The following is a description of a gene set: studied in species Homo sapiens Any process that modulates the frequency, rate or extent of the chemical reactions and pathways involving a protein. Human Gene Set: GOBP_REGULATION_OF_PROTEIN_METABOLIC_PROCESS, and this is the list of marker genes: PLAT, BANK1, TPR, IL15, SELENOT, SRC, NANOS2, CENATAC, CALCA, IL12A, VEGFB, EIF2AK4, DNAAF4, TAOK3, ELP5, FBXO2, NSD1, DDRGK1, APOE, IGFBP5, RPL38, ADARB1, CASS4, SERPINB12, KDR (NCBI Gene Id 3791), WNT7A (NCBI Gene Id 7476), SERBP1, PYM1, RASD2, BIRC8, TCIM, PAIP2, N4BP1, TRUB2, DAPK1, NECAB3, GTPBP4, LIMCH1, NEURL3, BIRC2, SYAP1, SNX1, MIR106B, PARP14, LATS1, FMN2, NUDT15, BCL10, LARP1B, PLCB1, OGFOD1, MAP3K5, SPOPL (NCBI Gene Id 339745), MAGOH, SSH1, GZMB, CEBPA, GAS1, TLR9, SMYD5, ABCG1, CNOT6L, MUL1, MIR181C, NCBP1, YBX3, ECM1, CNDP1, PDCD6, WTIP, ABCE1, MIR19B1, PER2, DHFR, ZBED3 (zinc finger BED-type containing 3), ERBB4, MIR98, ZAR1L, UQCC2, STK4, CLN8, PINX1, MKNK2, RASGRP1, DEFB114, EIF4A3, DUSP7, GAPDH, RWDD3, NCBP2, NOS2 (NCBI Gene Id 4843), CCDC22, FGF7, ELAVL1, PRKCE, JTB (NCBI Gene Id 23561), TCF7L2, HMG20A, MTBP, TRIM40, NCK2, CCR7, NKD2, CUL3, CDKN1B, LARP4, NGDN, FGA, BCAP31, IL20, SH3RF2, PTK2B, TLK2, MAGEA3, FRY, AGO2, FASTKD2, FGF19, AIMP2, ZCCHC13, MIR26B, DYRK1A, CASP3, IL21, SPON1, PAEP, BIN1, PIM1, COPS6, MYLIP, DERL1, MAP3K20, ADCYAP1, METTL3, F8A2, LPCAT1 (lysophosphatidylcholine acyltransferase 1), MAPK9, MIRLET7I, IBTK, TMEM259, MIR181D, SFN (NCBI Gene Id 2810), NEK10, EZH2, LSM14B, NLRP7, RASAL2, USP19, RAB3GAP2, MGAT4D, PUM3, RPS6KB1, PTPN3, TERF2IP, RPL5, IFRD2, WAC, ASB11, NEDD9, JAK2, SQSTM1, CD81, AGO3, RDX, MSI1, CNOT2, RNF185, PAXIP1, IL23R, USP4, ENC1, PFDN2, GCLC, ELP2, COP1, FN1, MIR204, PRKCG, CCL5, MIR152, EFNA1, CSNK2A2, TNIK, DHX29, PTPRJ, LILRB2, ASPSCR1, HDAC2, BAG6, HDAC4, PRKACB, ABCA7, CD300A, PLK3, SAMD4A, DIO2, CDKN3 (cyclin dependent kinase inhibitor 3), AKT1, ZNF418, PPIB, MT3, PABPC1, PIH1D1, FAXDC2, CPEB1, MOB1B, CDK5RAP1, TMX1, TP53, ABCA2, IL1B, EEF2K, CARD9, TSG101, SP1, SPINK5, CCNG1, MDM2, CACTIN, TARDBP, TSFM, NOD2, HMG20B, FHIT, PRKACA, OAZ2, UPF3A, FKBP1A, CPEB3, MVP, CAPRIN2, SENP1, DMTN, ITLN1, ERRFI1, TRIB1, LSM14A, CLN3, PLA2G10, MAPKAPK5, ADAM8, PACSIN3, MALT1, CTF1, ACOT8, RANBP9, DBI, GNL3, PABPN1L, PSMC1, PIWIL3, ZER1 (zyg-11 related cell cycle regulator), SUCNR1, CNOT6, EPPIN, ARRDC4, RIPK1, CAV3, UBB, PRLR, LTF, IFNGR1, BTRC, FADD, RFX4, UPF1, INSM1, KIF14, SMO, TIPARP (TCDD inducible poly(ADP-ribose) polymerase), RBM8A, WNT5A, BMP4, TMF1, SCRIB, GPRC5A, SERPINB3, MACROH2A1, MIR133B, KHDRBS1, APCS, MIR181A2, EIF2B4, MAPK7, STRADB, CUL4B, MIR17 (NCBI Gene Id 406952), PDCD4, EFNA3, STRADA (NCBI Gene Id 92335), PTTG1IP, CAPRIN1, SESN2, ELANE, DBNDD2, MIR106A, EIF4E2, RHOBTB3, MMD, PELI2, THY1, ARHGEF5, DHX9, MIR520C, TOM1L1, VPS25, NXN, CEP43, RPS3, DCUN1D5, CCNK, MIR214, TIMP4, DDX25, DDX1, FLOT2, RNFT2, RPS6KA2, PTX3, ITM2B, HHEX, UBE2K, CNOT9, TRIB3, ELP1, METAP2, RGS2, MAP3K4 (NCBI Gene Id 4216), MIR206, ROPN1B, CDC14B, VEGFA, RPS9, GPS1, DACT1, LILRA2, BOLL, ATRAID, ATG7, IKBKG, SVBP, NLRP2B, IRAK3, PSMD14, MIR125A, KLKB1, YWHAG, SPRTN, ECT2, ILF3, ATXN3L, KLHL31, SH3RF3, RAP1A, SERPINB8, IL10, CEP63, CASP8, BAG5, UBE2V1, AZIN1, SNCA, ARL2BP, SECISBP2, CNOT11, IAPP, PAIP1, EIF2A, MAP2K1, RAB1A, KDM4D, CTSA, FYN, COA3, NGRN, CD4, VIP, C2CD3, TSPYL2, BEX3, MUSK, EIF6, ANGPT1, RCC1L, SEPTIN4 (NCBI Gene Id 5414), CTSC (cathepsin C), ADIPOQ (adiponectin, C1Q and collagen domain containing), BEX4, PBK, CD84, PM20D2, ARRB2, NCSTN, C1QBP, PKD1, GSPT1, TNFRSF10A, MIR455, MAD2L2, DIRAS2, MDM4 (MDM4 regulator of p53), EPHA4, HGS, FGF1, NPM1, SERTAD1, COMMD1, RPS4X, PARD3, AJUBA, CDYL, RHOA, PAWR, PDGFRB, SUFU, RAP2C, RAB7A, RTN4, EDN1, CSNK1E, PIWIL1, NSUN5, PML, MIR199A1, DCUN1D2, CCNT2, SERPINE2 (NCBI Gene Id 5270), FLT4, OTUD6B, COPS4, CACUL1, PKIA, PSMD2, HNRNPD, BZW1 (basic leucine zipper and W2 domains 1), MIR134 (NCBI Gene Id 406924), ELP6, FZR1, PPP1R15A, UBA2, MIR339, RAMP1 (NCBI Gene Id 10267), FGFR1, BAG2, EIF4G1, PRG3, NR1H3, MIR29C, MIR874, TRIB2, CR1 (NCBI Gene Id 1378), CST4, PTCD3 (pentatricopeptide repeat domain 3), MIR644A, SRCIN1, ENO1, EIF4EBP3, IREB2, TSPAN15, CWH43, TAB2, FIRRM, TIA1, POLR2G, BACE2, DHFRP1, USP17L2, USP14, AATF, LDLRAD3, RPS7, COPS8, STYX, MIR101-1, CD86, TRIM44, NTRK2, NPPA, DISC1, PADI6, XRN1 (5'-3' exoribonuclease 1), MIR181B1, MIR378A, IGF2BP2, C8orf88, FKTN, BIRC3, TAF7, AIDA, CREBL2, PIK3C3, GPC3, BARD1, ACVR2A, RNF180, ZGPAT, PSMC4, PARP10, DDA1, HPX (hemopexin), UCN, UBE2C, MAP4K2, MIR200C (microRNA 200c), STAT2, COPS7A (NCBI Gene Id 50813), CHP1, TNK2, CNOT3 (CCR4-NOT transcription complex subunit 3), ARRB1, JAK3, SMAD3, TRAF3IP1, HSP90AA1, DEPTOR, TGFB1I1, XRCC5, SHMT1, MIR28, UBXN2A, PIN1, MIR146A, GSN, SEMG1, GADD45A, RTN1, CST3, NNMT, LYN, BCL2, HIF1A, MELTF, COPS3, SGSM3, RALB, ROCK1, MAPK8IP1, NR1H2, ITM2C, FBH1, DAZ1, DAXX, GLG1, RBX1, U2AF2, C4BPA, PDGFA (platelet derived growth factor subunit A, NCBI Gene Id 5154), LAT, DNAJB2, PRSS37, PINK1 (NCBI Gene Id 65018), RPS27L (ribosomal protein S27 like), USP16 (ubiquitin specific peptidase 16), VPS35, PTPN1, AQP11, DCUN1D4, GGA1, EIF5 (eukaryotic translation initiation factor 5), MSN, CNTN2, KRT13, RILP, METTL8, MTPN, APP, PRR5L, PLXNB2, MIR29A, WFS1, ZFP36, DHX36, FAM20A, LCP2, PRNP, CDK5R1, TYMS, PARP16, SRP9, IL23A, DNAJA3, RHBDD1, PSME3IP1, DAOA (NCBI Gene Id 267012), RNF41, SASH1, MIR27A, CASC3, NUPR1, RASSF2, CAB39, ZFYVE28, FBXL20, FBN1, TMED10, PHB1, MIR10B, HSPA5, OSBPL7, VCP, HERC5, MIRLET7A1, COPS9, TNFAIP3, KLF15, EFNA5, SNX6, NSF, TICAM1, FLT1, TPX2, MKNK1, RPL13A, MIR299, DIP2B, KSR1, DEDD, UBE3A, FBXL5, ITGB1BP1, IGF2BP1, RTRAF, MIR132 (NCBI Gene Id 406921), TNP1, ANG, FGR, ETAA1, ZFAND2A, THPO, BRAT1, CHI3L1, NRDC, TMEM98, CSDE1, MAP1A, SAE1, EDNRB, UBR3, KAT5, MIR148A, TIMP3, MIR21, GHRHR, MTA1, PUM2, CENPX, GABARAP, DUSP1, OPHN1, USP13, MIR590, MBP, DRD4, TMEM132A, RNF111, MYDGF, CEP295, USP7, TLR3, HIPK2, LRRTM3, TRNAU1AP, ROCK2, SEMA4D, GRIN2C, PIK3R6, CCNYL1, PLGRKT, KIT, COPS7B (NCBI Gene Id 64708), THBS4, BCL3, CRYAB (NCBI Gene Id 1410), ALKBH3, YBX1, DAB2, RNFT1, EEFSEC, PICALM, EIF1, GSK3B, SMAD4, CSF1, MIR126, DIPK2A, SARNP, TAF9, PUS7, MINAR1, CEP78, TGFB1, SIRT4, ODC1, NUB1, NHERF1, SUMO1, CSNK2B, TNFRSF10B, RNF128, PSENEN, MIR186, PTEN, GIGYF2, PAIP2B (poly(A) binding protein interacting protein 2B), ADGRB1, UBXN1, CBFA2T3, KDM1A, MIR20A, AURKA, EPAS1, SH3D19, ASB5, STK11, PCSK9, DAZ3, RUNX1, MIR153-1, BZW2, SPOCK2, ISL1, RPS6KA3 (NCBI Gene Id 6197), RACK1, USP26, STOX1, CDK5RAP3, GAS6, SOCS5, BLM (BLM RecQ like helicase), RAD23A, COPS5, SOX17, GPER1, CNOT1, FETUB, MALSU1, RASSF5, RPL23 (ribosomal protein L23), SHH, DGAT2, RIPK3, UBE2L3, MAPT, ATXN3, MAPK8, SLC6A9, MMP9, SH3RF1 (SH3 domain containing ring finger 1), CEMIP, EIF2B2, NEURL1, UCHL5, ASPH, CDKN2A, LARP1, LDB1, PRKCD, WASHC1, HSPB1, ALKBH1, PRKAA1, QRICH2, PSMC6, MIR323A, CTSZ, CAMLG, PSMC3, MAGEA2, DIP2A, KBTBD8, ATXN2, GCN1, CLEC3B, IDE, ERBB2, FBXW11, HSPBP1, PLK2, PIWIL4, SYK, SKP2, HSP90AB1, TTC36, TRAF7, ATF4, TNRC6B, ALKBH5, GRIN2A, IFT52, PSMF1, MMD2, ADAR, LARP6, PSME2, LRRK2, INS, TGFBR1, RTN3, TNFSF15, GNA12, LRIG2, FGFR3, FLNA, SLC51B, MIF4GD, RAP2B, PCIF1, OAZ1, TRIM67, SYNCRIP, PASK, TMTC3, TFAP4, NLRC4, RPS6KA1, SNX3, SKP1, FXR1, HSPA1B, CD80, MIR365A, CCDC134, TNFRSF18, S100A10, PTPN2, EIF4E3, RGS14, MIR448, VTN, EIF3B, MIR210 (NCBI Gene Id 406992), MYCBP2, RPUSD4, JMJD4, EIF3E, ARAF, PILRB, HABP4, TM4SF20, HBS1L, TANK, ABCB10, CAMKK2, FANCI, RAF1, CCDC88A, UBE2D1 (NCBI Gene Id 9335), RIPK2, BARHL2, RPS14, PPP1R15B, CIB1, USP25, CSNK2A1, P3H1, KCNE2, MAD2L1, SOX9, GATA1, CNOT7, WNK1, UNC119, MTM1, PRSS22, IER3, MIR659, TBX1, NAT10, SHMT2, MTG2, ATG14, TRAF4, MFSD8, FAM83D, ATG5 (autophagy related 5), ADCY8, PEF1, CNOT10, FECH, APOD (NCBI Gene Id 347), CEP85, CDKN1C (cyclin dependent kinase inhibitor 1C), CLSPN, MIR379, ANGPT4, CHEK2, CSNK2A3, CRIPTO, MIR135B, ACO1 (NCBI Gene Id 48), CDK20, CAV1, NGF, NKD1, IL1R2, BTG2, SENP2, ZDHHC2, LIPG (NCBI Gene Id 9388), RTN2, RECK, KLF2, USP5, CSTB, EIF4A2, PRKN, PFDN1, EIF5AL1, RPS2, AGAP2, WBP1L, XPO1, RARRES2, LRP1, ROPN1, BEX2, SLIT2, CYFIP2, FXYD1 (NCBI Gene Id 5348), LRP2, SMURF1, EIF4EBP1, PARK7, FLCN, LAPTM5, SOCS4, MIR345, MIR200B, HUWE1, AIRE, EGF, CAPN3, CDC37, HES1, RAD23B, NRG1, EIF2AK2, UBE2S, NANOS1, TRAF3, EIF3H, MIR499A (microRNA 499a), TRIM27, CYFIP1, NPTN, DESI1, BMAL1, CRTAP, PERP, FBXW8, RABL3, TENM1 (teneurin transmembrane protein 1), EEF1A2, MIR6086, WDR91, MIR361, EIF2AK3, RBMS3, EIF5B, NEDD4L, CREBRF, DAPL1, CRY1, TCF25, SPDYA, VBP1, TNFSF12, PKP3, TRIM71, TSPAN17, PIK3R5 (NCBI Gene Id 23533), EP300, CELF1, SEMG2, RFPL1, LRPPRC, EGR1, PRKCH, IFNG, TRAF6, PARL, PDCL3, COPS2, SERP1, MIR145, DCUN1D3, EPRS1, LAPTM4B, TIMP1, ZAR1 (zygote arrest 1), SIRT7, ELOB, PDGFB, SPOP, TSPO, CSF1R, ELP3, ZNF706, GPS2, PPIA, ATP5IF1, F8A1, NDFIP2, MIR212, F8A3, PRMT1, DIRAS3, CTIF, RCHY1, PURA, TRAF2, DTL, RYBP, MIR939, UPF3B, MSI2, ISG15, NANOS3, ROPN1L, DNAJA1, IL34, EIF1B, BIRC7, BBS7, CDH1, PIAS3, AMER1, USP44, SERPINB9, GLMN, BMP2, CHFR, MIR29B1, MIR15B, PIAS1, DCAF1, ANXA2, SERPINE1, MIURF, EGLN2, PKMYT1, TPD52L1, TRIM32, TMEM168, VPS28, BRMS1 (NCBI Gene Id 25855), MRNIP, SNX9 (sorting nexin 9), MAP3K7, SMG8, BMI1, CEACAM1, FBXO33, MIR100, PSME1, EEF2, IGF1, OAZ3, CNKSR3, FOXO3, CENPS, GIPC1, MTG1, SPOCK3, GBA1, CALR, ABL1, FBXO5, TF, GGA3, IVNS1ABP, PTPN13, ARHGAP5-AS1, TARBP2, CDC20, ALAD, MAPK1, GSAP, PKP1, AGO1, AKT1S1, MIR205, MIR15A, BRAF, GRN, GTF2H1, PRELID1, RARA, WARS1, AGBL4, SYNPO2, NQO1, ZNF598, HSPG2, EIF5A, IL33, CHRNA7, MIR503, CCAR2, LATS2, BAK1, PFDN5, MIR128-1, ITGAV, AKTIP, PROM2, WNT1, FBXW7, FANCM, CDK5R2, KLHL40, CDKN1A, RGP1, ERN1, CLU, GFAP, CUL4A, MIR520E, CORO1C, HDAC3, TRAP1, UHMK1 (NCBI Gene Id 127933), HERPUD1, CSPG4, AGER, PSME3, INPP5E, FMR1, XIAP, OSM, DDR2, CENPE, STK38, RHBDF1, PHF20L1, CPEB2, TOLLIP, PAK2, INHBA, ELP4, ARRDC3, CDC20B, CCNY, FOXF2, TSPYL5, DAPK3, RAPGEF2, GEMIN5, PFDN4, UNK, QKI, NFE2L1, MAP3K11, GSKIP, TBC1D7, TIFAB, ERCC6, CCBE1, SH3BGRL, TFR2, CCL21, MAP2K2, BCCIP, SEC22B, YTHDF1, HIPK3, EIF4H, WDFY2, SLC25A37, EIF2B5, NECAB1, TPPP, SERPINB13, MIR103A1, YTHDF3, NDUFA13, LACRT, NELL1, FGFR4, ACER2, METTL18, SIRT6, PSEN1, MIR218-1, NOLC1, ENSG00000293600, NCK1, PRMT3, SVIP, RIC1, ITCH, FGF2, CDK5, GOLGA2, LILRA5, PAQR3, PANO1, ITGB3, EIF2AK1, TSPAN5, PRKAA2, IGFBP3, MPV17L2, MIR877, CHMP6, TRIM6, CD74, EIF4ENIF1, FAM161A, ITGB2, TXN, SERPINB4, CARD14, METAP1, RCN3, MIR144, ZFP91 (ZFP91 zinc finger protein, atypical E3 ubiquitin ligase), PIBF1, CSNK1D, RBM4, CIRBP, ABI1, MIR27B, MTIF2, HRURF, AGO4, LIMD1, MIR346, SPHK1, MGAT3, CCNT1, CDK2AP1, XBP1, GUF1, RNF139, NECAB2, PLK1 (NCBI Gene Id 5347), HEG1, TIMP2, TLR6, DNAJC1, RPUSD3, ZFP36L1 (NCBI Gene Id 677), ODAM, TCOF1, RHBDD3, HRG, MAP2K5, NHLRC1, HMGCR, CARD10, SIRT1, NSUN3, PFDN6, UBQLN3, DCUN1D1, AXIN1, MIR495, TM9SF2, DAZ4, DIRAS1, EZR, RAB3GAP1, NDUFS4, GNL3L, NFE2L2, MIR125B1, ZNF385A, TNFSF18, SARS1, PYCARD, HHATL, MMP14, UBQLN2, SLC2A10, B3GNTL1 (UDP-GlcNAc:betaGal beta-1,3-N-acetylglucosaminyltransferase like 1), RALBP1, RGMA, STX5, PLAU, MIR141, PURB, MTOR, PSMC5, MAGEC2 (NCBI Gene Id 51438), IL11, KEAP1, FGF16, CNBP, SORL1, ARNT, SFRP2, SNRNP70, PLAA, C9orf72, MIR483, FAM107A, ARHGEF2, UFL1, IL31RA, VPS11, MARCHF7, CLIP3, RIDA, STUB1, RAP2A, KNDC1, CCL19, EIF4E, RPL11, MIR31, RAB1B, SF3B3, HLA-DRB1, APLP1, RPL10, PHIP, LARP4B, MIF (NCBI Gene Id 4282), ITM2A, FASTKD3, PITHD1, HAP1, DNAJC3, AZIN2, MIR298, A2ML1, DVL1, NEDD8, PIK3CG, FLT3, SHFL, USP38, TNFRSF1B, PYHIN1, WNT10B, CBLB, CDK2, CDC25C, ENPP2, FER, MUSTN1, TACO1, RBM24, MIR148B, CTNNB1, EGFR, PABIR1, SPRY2, PTPN22, SPSB4, PRMT6, FGF18, KLF4, INCA1, F12, WDR48, UBE2V2, PIAS4, INAVA, ZYG11B, SOAT1 (NCBI Gene Id 6646), RBM4B, HMGA2, MIR138-1, NOP53, FKBP8, GRB7, WT1, TNRC6C, CDC6, TRIM39, HNRNPU, MEN1, SERPINB1 (serpin family B member 1), MIR24-1, IL17D, YTHDF2, SFRP1, PHF23, PDCD10, RPS6KB2, TNRC6A, VGLL4 (vestigial like family member 4), SLC2A13, ACE, RMND1, PSMD3, EPM2A, SMAD7 (NCBI Gene Id 4092), APC, IMPACT, RBM3, C4BPB, AARS1, IL12B, TNIP1, POLDIP3, BEX1, MST1, PRKCA, AKT2, EPHA7, PELI1, RPL26, ADAM17, DDX6, CCNE2, HPN, EIF3K, TRIM21, RAC1, MAP2K3, MIR92A1, SUMO2, DAB2IP, KLHL25, SSB, HAMP, EIF4B, DAP, INPP5B, GTDC1, MIR147A, EIF2S1, ATP13A2 (ATPase cation transporting 13A2), TNF, EIF4EBP2, SIRT2, DYNAP, TREM2, PTK2, PRR16, HDAC6, CRB2, FBXO4, SGTA, GPRC5B, IRGM, ANGPTL8, ADAM9, ACP4, TBC1D10A, UBQLN1, AGTPBP1, DDX3X, CDK12, INPP5F, UBE2N, UFSP2, MIR1-1, USP9X, PA2G4, L3MBTL3, MAP3K10, OGT (O-linked N-acetylglucosamine (GlcNAc) transferase), IFNL1, ITGA2, C3, FLOT1, HECTD1, HSPA1A, VSIR, PLD1, TNP2, EIF5A2, ABCF1, CPEB4, DUS3L, FGF10, SNX12, PRKDC, NCL, INHBB, MRPL13, F2, KRT17, PPP2R3A, CD28, ASB9, TRMT10C, CYP51A1, BAD, PATL2, RELA, DAZL, MIR96, USP8, EREG, MIR182, FOXO1, THBS1 (NCBI Gene Id 7057), GABARAPL2, ASTL, PTPRC, DAZ2, ZNF540, GPLD1, PELO (pelota mRNA surveillance and ribosome rescue factor), FBLN1, KNG1, CFL1, DDB1, MIR9-1, GPX1, CNOT8, LIF, HDAC8, PSMD10, MST1R, CSTA, MARCHF6-DT, PSMC2, EIF4E1B, LAMP3, IST1, PUM1, NMI, CHAC1, FURIN, NMNAT2, SAMD4B, NEDD4, ZCCHC4, NSMCE3, MIR221, METTL14, AGT, LDLR, FSCB, RIGI, TMEM9, IGF2BP3, MIR16-1, ECSCR, ZC3H12A, PLAUR, PPM1E, EIF4G2, NDFIP1, MIR208A, UBQLN4 (NCBI Gene Id 56893), DET1, UVRAG, MIR1271, NT5DC2, SERPINF2, SNX33 (sorting nexin 33), MYH9, ETF1, CNTF, EEF1A1, DTX3L, CAMK1, PTK6 (NCBI Gene Id 5753), SIAH2, CSNK1A1, AURKAIP1, SAMSN1, GSK3A, CADM4, DOK7, IL18, SNF8, FBXO22, PXYLP1, TENT5B (NCBI Gene Id 115572), S100A12, ADRA2A, EIF3C, RB1, MIR107, IL17F, YBX2, PFN2, NIBAN1, HFE, XRCC6, RASSF1 (NCBI Gene Id 11186), SEPSECS, FAF1, RASIP1, S1PR2, PKM, MAGEA2B, OTUD4, UHRF1, PSMD1, LIN28A, TOB1, EIF4G3, PARP9, CLN6, LEP, ZNF268, MRPS27, WNK3, SMARCC1, ALS2, IL6, RSPO1, UBE2B, MIR520B, MARCHF2, PIWIL2, METTL5, TAF1, AXIN2, PRICKLE1 (NCBI Gene Id 144165), PPP1CA, CELF4, FXR2, CDC25A